Given this list of marker genes BRD2, IL23R, PRKCQ, IL12B, NFKBIZ, CARD9, IL12RB1, ARID5A, MALT1, NFKBID, JAK2, TYK2, CLEC6A, EP300, MIR21, OPA1, BRD4, NLRP10, CLEC7A, IL23A, here is a description of the gene set: species: Homo sapiens Human Gene Set: GOBP_POSITIVE_REGULATION_OF_T_HELPER_17_TYPE_IMMUNE_RESPONSE Any process that activates or increases the frequency, rate or extent of T-helper 17 type immune response.